Given this list of marker genes PPP2R5C, KSR1, PPP2R5B, CALM1, KRAS, PPP1CB, PPP2R5A, YWHAB, HRAS, MAP2K1, JAK2, PPP2R1B (NCBI Gene Id 5519), CAMK2B, PPP2R1A, MRAS, PPP2R5D, RAF1, PPP2CB, CAMK2A, MARK3, BRAF, MAP2K2, CAMK2D, NRAS, SHOC2, MAP3K11, PPP1CC, BRAP, SRC (NCBI Gene Id 6714, SRC proto-oncogene, non-receptor tyrosine kinase), CAMK2G, PPP2CA, ARAF, PHB1, PPP2R5E, here is a description of the gene set: Mammals have three RAF isoforms, A, B and C, that are activated downstream of RAS and stimulate the MAPK pathway. Although CRAF (also known as RAF-1) was the first identified and remains perhaps the best studied, BRAF is most similar to the RAF expressed in other organisms. Notably, MAPK (ERK) activation is more compromised in BRAF-deficient cells than in CRAF or ARAF deficient cells. Consistent with its important role in MAPK pathway activation, mutations in the BRAF gene, but not in those for A- or CRAF, are associated with cancer development. ARAF and CRAF may have arisen through gene duplication events, and may play additional roles in MAPK-independent signaling.<br>Despite divergences in function, all mammalian RAF proteins share three conserved regions (CRs) and each interacts with RAS and MEK proteins, although with different affinities. The N-terminal CR1 contains a RAS-binding domain (RBD) and a cysteine-rich domain (CRD) that mediate interactions with RAS and the phospholipid membrane. CR2 contains inhibitory phosphorylation sites that impact RAS binding and RAF activation, while the C-terminal CR3 contains the bi-lobed kinase domain with its activation loop, and an adjacent upstream "N-terminal acidic motif" -S(S/G)YY in C- and A-RAF,respectively, and SSDD in B-RAF - that is required for RAF activation.<br><br>Regulation of RAF activity involves multiple phosphorylation and dephosphorylation events, intramolecular conformational changes, homo- and heterodimerization between RAF monomers and changes to protein binding partners, including scaffolding proteins which bring pathway members together. The details of this regulation are not completely known and differ slightly from one RAF isoform to another. Briefly, in the inactive state, RAF phosphorylation on conserved serine residues in CR2 promote an interaction with 14-3-3 dimers, maintaining the kinase in a closed conformation. Upon RAS activation, these sites are dephosphorylated, allowing the RAF CRD and RBD to bind RAS and phospholipids, facilitating membrane recruitment. RAF activation requires homo- or heterodimerization, which promotes autophosphorylation in the activation loop of the receiving monomer. Of the three isoforms, only BRAF is able to initiate this allosteric activation of other RAF monomers. This activity depends on negative charge in the N-terminal acidic region (NtA; S(S/G)YY or SSDD) adjacent to the kinase domain. In BRAF, this region carries permanent negative charge due to the presence of the two aspartate residues in place of the tyrosine residues of A- and CRAF. In addition, unique to BRAF, one of the serine residues of the NtA is constitutively phosphorylated. In A- and CRAF, residues in this region are subject to phosphorylation by activated MEK downstream of RAF activation, establishing a positive feedback loop and allowing activated A- and CRAF monomers to act as transactivators in turn. RAF signaling is terminated through dephosphorylation of the NtA region and phosphorylation of the residues that mediate the inhibitory interaction with 14-3-3, promoting a return to the inactive state.<br> Reactome Pathway: RAF activation species: Homo sapiens part of: RAF/MAP kinase cascade